Given this list of marker genes Suclg1, Sdhb, Sdha, Suclg2, Gad2, Sdhaf3, Sucla2, Aldh5a1, here is a description of the gene set: studied in species Mus musculus The chemical reactions and pathways involving succinate, also known as butanedioate or ethane dicarboxylate, the dianion of succinic acid. Succinate is an important intermediate in metabolism and a component of the TCA cycle. Mouse Gene Set: GOBP_SUCCINATE_METABOLIC_PROCESS